Given this list of marker genes Mettl3, Rbm4 (RNA binding motif protein 4), Ythdf2, Eif4ebp1, Nck1, here is a description of the gene set: The process where translation initiation recruits the 40S ribosomal subunits in a Cap and 5' end independent fashion before an AUG codon is encountered in an appropriate sequence context to initiate mRNA or circRNA translation. species: Mus musculus Mouse Gene Set: GOBP_CAP_INDEPENDENT_TRANSLATIONAL_INITIATION